Given this list of marker genes FCMR, ARAP3, ESYT1 (extended synaptotagmin 1), PCBP2, LINC00926 (NCBI Gene Id 283663), COQ8A, ZNF395 (zinc finger protein 395), BBS2, SGK1, VEZT, BRI3BP, here is a description of the gene set: from publication Matsumiya M, Harris SA, Satti I, Stockdale L, Tanner R, O'Shea MK, Tameris M, Mahomed H, Hatherill M, Scriba TJ, Hanekom WA, McShane H, Fletcher HA (PMID 24912498) Human Gene Set: MATSUMIYA_BLOOD_MODIFIED_VACCINIA_ANKARA_VACCINE_AGE_4_6MO_VACCINATED_VS_CANDIN_PLACEBO_BCG_PRIMED_1DY_DN studied in species Homo sapiens BACKGROUND: Tuberculosis (TB) remains a global health problem, with vaccination likely to be a necessary part of a successful control strategy. Results of the first Phase 2b efficacy trial of a candidate vaccine, MVA85A, evaluated in BCG-vaccinated infants were published last year. Although no improvement in efficacy above BCG alone was seen, cryopreserved samples from this trial provide an opportunity to study the immune response to vaccination in this population. METHODS: We investigated blood samples taken before vaccination (baseline) and one and 28 days post-vaccination with MVA85A or placebo (Candin). The IFN-gamma ELISpot assay was performed at baseline and on day 28 to quantify the adaptive response to Ag85A peptides. Gene expression analysis was performed at all three timepoints to identify early gene signatures predictive of the magnitude of the subsequent adaptive T cell response using the significance analysis of microarrays (SAM) statistical package and gene set enrichment analysis. RESULTS: One day post-MVA85A, there is an induction of inflammatory pathways compared to placebo samples. Modules associated with myeloid cells and inflammation pre- and one day post-MVA85A correlate with a higher IFN-gamma ELISpot response post-vaccination. By contrast, previous work done in UK adults shows early inflammation in this population is not associated with a strong T cell response but that induction of regulatory pathways inversely correlates with the magnitude of the T cell response. This may be indicative of important mechanistic differences in how T cell responses develop in these two populations following vaccination with MVA85A. CONCLUSION: The results suggest the capacity of MVA85A to induce a strong innate response is key to the initiation of an adaptive immune response in South African infants but induction of regulatory pathways may be more important in UK adults. Understanding differences in immune response to vaccination between populations is likely to be an important aspect of developing successful vaccines and vaccination strategies. TRIAL: ClinicalTrials.gov number NCT00953927. Genes down-regulated in blood vaccinated vs candin placebo in infants (4-6m) (BCG-primed) after exposure to Modified Vaccinia Ankara (MVA) virus vaccine vector, time point 1D